The following is a description of a gene set: from publication Yevshin I, Sharipov R, Kolmykov S, Kondrakhin Y, Kolpakov F (PMID 30445619) studied in species Homo sapiens Genes containing one or more binding sites for (ZSCAN4) in their promoter regions (TSS -1000,+100 bp) as identified by GTRD version 20.06 ChIP-seq harmonization. Human Gene Set: ZSCAN4_TARGET_GENES, and this is the list of marker genes: LINC01800, LCP1, GPR156, IL10RA, ZNF567, SMN1, SLC16A5, ARHGEF1, MYL6B, PPCDC, HSPE1, SNORD65C, MEIS3P1 (Meis homeobox 3 pseudogene 1), GOLIM4, TRAV12-1, SMG7-AS1, BOC, PRECSIT, DLX3, TSSK3, HECW2, FAM107B, PRSS23-AS1, STK40, DOC2A, ENSG00000233017, FGD3, LINC01482, UBE3C, HDAC2-AS2, WEE2-AS1, BBOX1, ABHD4, LINC01237, SHISA5, PPM1D, BAG6, IGF1R, RPL26, FAM168A, ZNF827, RNF128, SEPTIN5, SLC44A1, CHRM2, HSDL2-AS1, MDGA1, PLEKHG2, BDP1, GSDMA, HS3ST3B1, DDX1, PGM5P3-AS1, TTC9-DT, ZNF540, NREP, PRPF40B, LINC01366, HOXA3, SSBP4, MIR3677HG, ADRA1A, ALG1, TMEM242-DT, AXL, USP36, ALDH3A1, MSH5, MCOLN1, ECE1, SRP72P2, SERP1, KASH5, TGFB3, DNAJB13, RAP1GAP2 (RAP1 GTPase activating protein 2), TMEM175, CSGALNACT1, HDAC7, ZSCAN16, MSC-AS1, MIR1302-5, TUBA1A, TENM3-AS1, H2AC25, SORT1, INTS9, BLOC1S2, LEMD1, PSD2-AS1, TTC5, LINC01354, EDC3, MAPK10, PCBP2P3, SIPA1L2, RAB5B, PHF1, PTK2B, NSD3, GOLGA6L6, NME1, ELAVL2, LSAMP, HEXA, ZFHX3, SLC7A11, GCC2, CDKN2B-AS1, PAX6, CEP43, RIMBP3C, RGS14, SLCO5A1, ISLR2, NBPF25P, TMEM255A, MTA1, ASXL3-DT, MTFR2P2, PSG5, FAN1, KREMEN1, GJC1, SLC6A15, TARS2, HYCC1, S100A14, C10orf67, POU6F2, DMTN, H2BC15, ITGA9-AS1 (ITGA9 antisense RNA 1), NLGN1, TMEM198B, WDR53, LIN28A, HMOX1, PCSK1N, ZNF345, WWTR1-AS1, APOBEC1 (NCBI Gene Id 339), HSPE1-MOB4, NBR1, SH3KBP1, SNORD74B, RNU6-1110P, PDCD4, ETV4, MIR4276, PSG4, GTF2IP12, KRT7, RBFOX2, DUSP2, TBC1D4, HERC1, RNU6-859P, ATP5MF, PRKG1, GAPDHP71, HEXA-AS1, INTS12, KCNJ5, SCG5-AS1, INO80D-AS1, TCF4, PGM5, RAB11FIP1, MECOM, LRRC45, RBM28, SOX9-AS1, HAPLN1 (hyaluronan and proteoglycan link protein 1), RFX3, GNAL, KCTD5 (NCBI Gene Id 91152), LINC01664, SYBU, MEIS2, C16orf89, FGF9, BRF2, JPX, HDAC5, PRELID1P5, ENSG00000267448, SLC4A1AP, EIF4G1, ENSG00000276170, FGR, PANK1-AS1, LTF, LDLRAD4, JRK, FAM53C, ATG16L1 (NCBI Gene Id 81560), PRPF19, ELN, ISM2, PRKAR1B-AS2, TMCC2, BRSK2, ITGB2, SYT14, DTNBP1, NFIA-AS2, BIRC3 (NCBI Gene Id 330), EBF1, SF3A3, GUK1, HIF3A, IPO11, OSBPL10, FGF7, HIPK2, STMN4, DACT3-AS1, RNPS1, MRPS31P5, ENSG00000225457, ABCC12, BRSK1, MINAR1, MSANTD3, MED23, ALDH5A1, POLR1A, CFL1, DOCK5, EIF2B5, RYR3, UBE2Q2P1, SNRPGP10, GNB2, HAUS5, ZNF513, TGFB2, LRWD1, ZBBX, ATP6V0A2, HOXA10-AS, SGCA, CASC3, LRFN3 (leucine rich repeat and fibronectin type III domain containing 3), MGLL, ST7L, MDFI, CERS5, TXLNB, MIR615, STXBP5L, CXXC4, ZSWIM9, BCL9L, BBC3, SYN2, VSIR, ARHGAP23, SRP54, HUWE1, PEF1-AS1 (PEF1 and COL16A1 antisense RNA 1), SUMF1, CSAD, SLIT1, FSTL3 (NCBI Gene Id 10272), TAB1, CDC42SE1, ZNF461, NR3C1, SLC8A2, GARS1-DT, MGST2, ARID1A, MASP1, DTX4, ELOVL2-AS1, RPS3AP42, RAB2B, JCAD, SSC5D, TRIM52, CEROX1, LASTR, CACNA1D, RNA5SP259, PIWIL4-AS1, KIF11, HAS1, IL2RB, HACD1, SPX, ARAP3, HMX1, FAM117B, MAGI2-AS3, HSPBP1, KCNIP2, TSKU, LGI4, CPEB4, WWTR1, RNF150, RCOR3, ACP2, PHLDA3, ONECUT1, CASP7, FAM151B-DT, STMN3, CARM1, EXOSC7, BSG, RASGRP3, ANXA2, SMG6-IT1, RBM39, VGLL4, ADGRG2, CLASP2, RAI2, LINC01229, IL17REL, TMEM242, KCNH7, ITPRIP, GNAO1, NOS1, INTS14, ATP6V1B2, CTTNBP2, BNC2-AS1, THA1P (NCBI Gene Id 390816), NOTCH2NLA, TFAP4, MIR1301, NSD2, CLPB, TOX4, ENSG00000267260, RNPC3, HOXD3, ATP1A3, NOMO1, SLCO5A1-AS1, HP1BP3, TOR1A, ATPAF2, CARD10, MEIS3, NUTM2B-AS1, FNBP1P1, FBXO45, ZNF395, PBX1, BHLHE40, TRIM2, COL6A2, RAMP3, GBA1, NCR3, PLA2G4A, CHD1, COQ3, MAB21L3, SNAP47, RAB40B, DAZAP1, ARHGAP1, SIGIRR, CEP85, ZNF780A (zinc finger protein 780A), CACYBP, UBE2Q2P12, LINC03068, FYN, CYLD-AS1, VAV1, WDR83, GCC1, RNF220, FAHD1, SSPOP, ATAD3A, GFRA1, TRPA1, LRRC27, FGF13, CELF6, OVGP1 (NCBI Gene Id 8684), TSPAN18, PVALB, CHRNA4, ZNF391, SYNGAP1, ARRB1, KCNJ10 (potassium inwardly rectifying channel subfamily J member 10), CSMD2, DZIP1L (NCBI Gene Id 199221), IRF2-DT, TAF8, CEP170P1, MANSC1, TESMIN, BCLAF1, JARID2, BCL2L13, CABP1, EIF2B3, ALDOA, DCN (decorin), CALCRL, TNFSF12, ZNF331, TSHZ2, ENSG00000249236, GAS7, SEMA6D, DUSP26, ZNF608, ADGRE2, NRN1, EMID1, BBX, SBF1P2, NTF3, WNT5A-AS1, RBFOX3, SOX8, CTNNB1, DHRS13, EXOC3L4, ZNF790, GNAQ, LZIC, BLK, CACNA2D4, SORCS1, RPS27, CTF1, SRFBP1, CENPBD2P, RNU6-918P, SLC7A10, ZYG11A, INIP, SCRT2, GRIPAP1 (GRIP1 associated protein 1), ASPG, PHF21B, SCAP, AFTPH, KRT18P12, MIR6792, KIAA1671, CEBPG, PIPOX, IKZF4, SMYD5, NCOR2, CTF2P, BLTP3B, LINC01235, FAXC, FXYD5, TGM2, ZNF440, DIXDC1, CECR2, NR2F1, ENDOU, CDCA3, TGFBR3L, MTFR1L, PEF1, C2CD5, GNA15, MAML3, PLXDC1, EIF2AK3, MAP2K2, ACVR2A, ANGPT4, HOXD10, CASC9, CHRNA2 (NCBI Gene Id 1135), CEBPB-AS1, LIMCH1, PSTK, SYNPO2, ADGRE5, KCNQ2, KLHL32, HOOK1, GPR89A, C8orf74, LINC01671, IER5L-AS1 (IER5L antisense RNA 1), CAV2, SPRED1, CCDC66, SPG21, GREM2, CHUK-DT, NUTM2A-AS1, KLKP1, MBTPS2, MAD2L1BP, ZKSCAN3, NRON (NCBI Gene Id 641373), TSC1, WNT10A, MIR221, LINC02914, MPPED2, GOLGA6L22, WDR25, LINC02709, NR1H3, ATP5MFP1, FBXL17, SLC1A3, DENND4B, TMEM41A, PROX1-AS1, ZNF860, NTS, ABHD14B, RNU7-27P, DLL3, MRPL39, LINC01270, CASZ1, TMEM25 (NCBI Gene Id 84866), ACBD5, BCL7C, IRF2, NDUFA2, FXYD1, ZNF780B, ERCC1, H2AZP1, SEC14L5, LINC00933, LINC01227, CNTFR, SSBP1, MIR1253, SPPL2B, LINC00431 (NCBI Gene Id 104355135), LAMA3, BTF3-DT, SMG7, SLC36A4, EGLN1, PAK3, RNU6-1145P, ZNF432, MPO, GEMIN6, SLF1, LINC01124, HERC3, TAL1, ASB13, LAMP1, PRR7, INO80B-WBP1, SEMA6A, CD5, GRK1, OBSL1, DMAP1, MRPL1, GABBR1, ENSG00000235281 (novel transcript), LRRK2, XKR9, SMN2, CCDC142, ABCA15P, GGT1, AVPR2, SFMBT2, MSRB2, ATP8A2, RIMBP3, RPS14, NFYC, ADGRG7, KMT2D, SUPT7L, BPI, SLC24A1, CD6, ZNF217, SAP30-DT, ANKRD24, TENM4, FAM27B, GSPT1, ANP32E, C3orf52, DRG2, RPAP3, TRPA2P, ARAP1, LIMD1, EVI5L, AGAP3, SLC35A2, KIF17, EPHX2, HCG27, HEXIM1, GSTCD, UTS2B, LRFN2 (NCBI Gene Id 57497), TUBB2A, MRTFB, LINC01267, SH3BP1 (NCBI Gene Id 84161), NUP98, MEG3, ST8SIA1, CDK2AP1P1, NGEF, KLF7 (NCBI Gene Id 8609), NUCKS1, STRBP, CHRNE, PREX2, FABP5, ITGA8, PPP1R1C, RHCE, TFDP1, IRAG2, RAB11FIP5, CIMIP5, LIN9, PLCB4, ARHGAP28, TNS1, SPATA42, FAM76AP1, PHF12, ATP2B4, ZNF536, UBA1, CRMP1, FBXW7, PYM1, GRB10, FAM98C, TRHDE, OSBPL3, GPC6, SPECC1L, NR1I3, C1orf21-DT, APOLD1, RAB7B, PRR29-AS1, NPEPL1, ASL, DST, PPP3R1, SPINT1, MTAP, LNMICC, FOXP2, HIP1R, HMGB1P21, MACO1, TBXAS1 (NCBI Gene Id 6916), IZUMO1, LCORL, MAX, IK, NFKB2, SMAP2 (small ArfGAP2), MTMR1 (myotubularin related protein 1), SEPTIN9, TBPL1, NHEJ1, EFNA3, CUL2, SIRT6, LINC01107, TPM3P7, KPNB1, KGD4, GPR183, RBBP5, U2SURP, SYN3, MAPK1IP1L, COQ4, CDHR17P, LINC03047, BMF, HNRNPH3, CCND3, SNRNP35, KIAA1217, IRAK4, EPB41L2, CNOT4, BCL7A (NCBI Gene Id 605), SORBS3, EXD2, LINC02845, TRDMT1, SYBU-AS1, KMT2E, FREM1 (FRAS1 related extracellular matrix 1), TMEM182, SHKBP1, NANOGP4, TEFM, FRA10AC1, DMC1, EGLN3, WDR83OS, CCAR2, NHLH1, EPB41L3, SPTBN4 (spectrin beta, non-erythrocytic 4), TRIM62, MGRN1, MYO19, SMYD3, LRRC63, ABCG2, KCNK1, RIMBP3B, ERAP2, ADAMTS19, NHSL3, GRIN2B, FRAS1, RNVU1-15, TMEM91, C6orf226, KLHL23, PPP1R12C, PPIAP74, WSCD1, TMEM238L, PIK3C2B, RFX1, MIRLET7BHG, LRRC74B, CUEDC1, R3HDM2, KIF22, COPZ1, RAET1E, ATP5MC1P7, TAF4, FGD2, ITGA7, ASXL3, IRF2BPL, CITED1, GAPDHP45, ALKBH3, CGREF1 (NCBI Gene Id 378765), GLIS3, LIG1, TMEM100, GRIN2D, NFIB, SNORA72, RS1, AURKAIP1, SAP30, ANK2, SOX5, TTC9, LINC02011, ARHGAP6 (Rho GTPase activating protein 6), THUMPD1 (THUMP domain containing 1), STXBP2 (NCBI Gene Id 6813), UPRT, NUMA1, GPR78, HPDL, NDNF, NOMO2 (NODAL modulator 2), NEFL, RPL23AP66 (ribosomal protein L23a pseudogene 66), PTPRZ1, RHOXF1P3, ARL8A, SLC15A1, MAP3K13, L3MBTL2, PLAAT3, SLC5A2, EPHA10, COPZ2, HAS2, ZFHX4, DPYSL3, GABRB2, GABPB2, SLC6A9, GFI1B, COLQ, RGS5, MTND4P18, NPAS3, ZNF571, KCNJ12, SSH2, EIF2D, TAB2, PAOX, HNRNPU, SOX9, VIT, BCAN-AS2, SAMD14, LINC00963, SYT8, SHANK2, IGLV3-32, SERPINE1, PDE1B, TLK2, OTULIN-DT, MMP16, TRIM7, NOMO3, SMARCA2, PPP3CA, ATP5MF-PTCD1, CDO1, RBMS1, PRKCB, TSC22D4, CUL4A, INO80B (INO80 complex subunit B), CKAP5, MAN2C1, STARD3 (NCBI Gene Id 10948), FCMR, ZCCHC24, TRBV7-6, CYBC1, TCF3, ZNF408, UBAC2, YJU2, MAEL, HPS4, KIRREL2, TLE3, ZBTB4, NAGPA, SMAD7, GTF3C5 (NCBI Gene Id 95853), MXI1, PHF21A, LZTS1, TNNI1, UNC93B1, POLD2, TMSB10, HAS2-AS1, GPR85, SAMD13, GRM1, GGA2, RCOR1, CHRDL2, STUM, SEMA4F, JOSD2, RNU6-1039P, ARHGEF16, NHSL2, JADE2, DAAM1, USB1, RNU6-419P, CTSK, SKP1, LBX1-AS1, CSF1, COMP (cartilage oligomeric matrix protein), DDX55, HIVEP1, ATP2A1-AS1, ATXN1-AS1, DNHD1 (dynein heavy chain domain 1), FAM124A, PLAT, CMTM3, PBX3 (PBX homeobox 3), HMGN3P1, USP9X, MIR6726, IL6R, NDRG1, AMOTL2, DNAJB12, TRIM52-AS1, SPATA13 (NCBI Gene Id 221178), PAX3, GID4, GAL3ST4, KCTD1, CMAHP, PDE4B, FAM43A, RTN4RL2 (NCBI Gene Id 349667), SANBR, SPSB1, SLC35A3, GLYCTK (NCBI Gene Id 132158), ZNF382, ZNF84-DT, LMBR1L, SAXO3, RRN3P2, EIF2B4, HEBP1, NPHP4, NADK2, RAD52, KCNAB2, PTCD1 (pentatricopeptide repeat domain 1), PIGC, ZNF529-AS1, KLHL6, PLEKHG1, SNHG11, PCID2, G0S2, CALCP, HOXD8, IAH1, RN7SKP172, RUNDC3B, NFE2L1, CHRFAM7A, MTMR2, ENSG00000270571, NDUFAF1, HADHA, FMNL1, GDNF-AS1, PLCXD2, NFIX, ITGAM, NFKB1, EMB, ZNF45-AS1, EIF4E3, ETS2, LSM12, LCNL1, CABIN1, ASPSCR1, MYL6B-AS1, PSG11, TTC17, PDE4A, TMEM101, FCHSD2, RGS16, ENSG00000267058, MAF, SELENON, FGF8, PRKCE, GPR162, ENSG00000253607, FHDC1, ARHGEF15, ZBTB38, TSKU-AS1, RERE, OGT, FGF1, BORCS8, NPR3, BRWD1, RFX4, CERS6, KBTBD4, TOP2B (DNA topoisomerase II beta), REXO4, VPS33A, ROPN1, NUF2, UBR2, HMGB1, GTF2B, HAGH, C8orf34, IFNLR1, RPL29, TUBA1C, CD59, JMJD4 (NCBI Gene Id 65094), MAGI2, WDR11, ADIRF, LHX9, NTRK2, NBPF19, DNAJC14, C6orf136, PUS7L, LMO1, BCL2, GRIA2, PPP2R2B, ARHGEF7, PFKL, NOTCH2 (NCBI Gene Id 55574), LINC01605, WEE2, CBR3-AS1, TLCD3B, PLA2G6, ENSG00000243004, SHROOM2, NR2F6, PIK3R3, ZNF529, PNCK, LINC00163, ADNP, DGKG, CRYZL1, RYR3-DT, PDGFB, KCNK10, ENSG00000247416, DTNA, HPCAL1, BTBD19, MSI2, LRRC37B, STAT6, SLC26A4, HPCA, GHR, PKNOX2-AS1, VANGL1, SH3BP2, MAFTRR, MRPS31, TMEM248, EIF3D, RFX3-DT, C11orf96, FOXP1, ARRB2, RUFY1, GNB5, ANK3, ITGB3BP, KSR2, CPNE5, TMEM177, SRSF7, LIMS1, PAX1, MIR378A (microRNA 378a), LINC01003, ZNF546, PLIN3, GAK, FANCC, EBF4, FAT3, CDKL5, KIAA1958, LINC02912, LEPROT, AGBL3, CCNY, LHX6 (NCBI Gene Id 26468), RIMKLB, PAQR9, RCN1, MIR548AW, RBM26, RN7SL310P, LMF1, KIRREL1, CD109, NRIP2, NUDT18, KCNH2, PDZD8, EXOSC3, RABGAP1L, PLA2G10P1, DPH5, RASGRF2, BMP3, PFKFB4, ARHGEF17, ZBTB44-DT, NRG1, DENND2A, PLCH1, CTXND2, CPVL, HSPD1, TBC1D14, RNU6-513P (NCBI Gene Id 106481343), MREGP1, FBXO32, ZFP30, HOXA9, SPOUT1, TRAV12-2, EXOC7, NDUFA5P3, COX16, CCDC146, SNAP25, GDF5, IKBKE, ENSG00000261335, DNAH2, TMEM178A, HOXA-AS2, SCN9A, SNX1, FEZ1, MAPT-IT1, PRRT4, LINC02716, RNU6-570P, RBM26-AS1, IL11RA, DCDC2, CCNE1, CCN3, RAVER1, CHST13, FOXN3, IL1R1, SOX2-OT, GALNT16-AS1 (GALNT16 and EXD2 antisense RNA 1), MSH5-SAPCD1 (NCBI Gene Id 100532732), TOP3B, PDZK1IP1, HMGA1P3, CYLD, IPO9-AS1, HOXC5, PBX3-DT, CD300A, PRSS8, ASIC1, MARCKS, FAM149A, NR2F1-AS1, WNT5A, SPN, CCNI (cyclin I), HS3ST3A1, ZNF740, SCML4, ASB9, STRN, ATP13A2, TRUB2, XKR6, SPAST, TANC1, TBL1XR1, MDGA2, UBE2QL1, EPS15L1, SH3D19, MTUS2-AS1, YARS1, EZH2, MEIS1, LINC01503, NFATC3, SP5, TMEM74B, PJA1, KCTD15, MADD, SPTSSA, BTF3, DIO3OS, TMEM204, DUOX1 (dual oxidase 1), DNAJC5B, IFT56, CDC25C, TIAM2, SMURF1, NOP16, PANK1 (pantothenate kinase 1), DNAJB4, GTPBP3, LEPR, GRAP2, ELP3, ENSG00000248738, ZHX3, HADHB, RHOB, ABI3BP, CLDN1, RCBTB2, ARHGEF28, LURAP1, BORCS8-MEF2B, HYAL4 (NCBI Gene Id 23553), GPM6A, TRARG1, HDAC2, FRMD4B, LMO2 (NCBI Gene Id 8051), LRRC49, NECAP1, GCDH, ZMYND8, SLC22A11 (NCBI Gene Id 55867, solute carrier family 22 member 11), APOD, SEPTIN7P14, R3HCC1L, LINC02332, CSNK1D, CUL9 (cullin 9), GLMP, LEF1, JPH2, F11, DIS3, MGAT1, OR1N2, GCNT2, DCAF1, NFE2L1-DT, CCDC171, PLCB2, ENPP3, DGKK, MYL6, KCNIP1, MAFF, HOXA-AS3, CMIP, RIPOR2, FOXS1, EFCAB7, RN7SL743P, RNU6-470P, VAC14, NME2, CHD3, SEMA3G, ELF2, ADAM10, ANO8, PRDM6, RASGRF1, SLX9, FCHO1, ZFHX4-AS1, BMS1, RAPGEF6, RNF217, GNLY, SCD, MIR6802, USP30, TRBV7-2, ZNF84, ITSN1, ABR (NCBI Gene Id 82701), INSYN2B, PISD, FENDRR, PRICKLE2-AS3, PPIE, LASP1, LINC01781, SOX13, EID2B, BCORL1, SP8, DYRK1A, NCAM1, MSC, PSG8, PAQR9-AS1, PFKFB3, WDR45B, CDC37, CNOT6L, ENSG00000203900, RBM22, SRGAP3, SMARCD3, PLAAT1 (phospholipase A and acyltransferase 1), INHA (NCBI Gene Id 3623), CLDN7, PPP6R1, UBB, ITPK1, WDTC1-DT, LACTB, LLGL2, SEC22B, NMNAT1, RASA1, MLLT11 (MLLT11 transcription factor 7 cofactor), LINC-ROR, CDC42EP4, SLC6A8, NUP160, LEF1-AS1, SFXN5, LHFPL1, TAB2-AS1 (NCBI Gene Id 105378049), VSTM2L, ARHGAP24, ACTR6, LINC01547, NF1, TGFB2-AS1, PCBP2, RTEL1, LDB1, ADAMTS10, LIX1L, TXK, LIPE, RBFA, ACSM1, TRPV1, LINC02268 (long intergenic non-protein coding RNA 2268), NFIC (nuclear factor I C), UGGT1, GPAM, C17orf58, KLHL20, NANOS3, PAFAH1B3, DDR2, ST8SIA4, RTBDN, RARG, CCN5, SERPINA11, ENSG00000232995, POU4F1, DYNC2I2, MACC1-AS1, KLHDC9, MCRS1, TCF7L1, RNU2-17P, UBE2K, TMEM121B, WDR82, NME1-NME2 (NME1-NME2 readthrough), CPED1, ERC1, DISC1 (DISC1 scaffold protein), LINC00322, EMP2, WDR11-DT, S100PBP, RLN2, VOPP1, SLC16A7, APOM, ZSWIM2, LSG1, NFKBIE, MID2, CTU2, ENSG00000259881, ENSG00000250915, ARVCF, CEACAMP4, MIR4418, C17orf75, CDC14A, VPS51, TBPL2, HECTD1, CFDP1, TTC36-AS1, PRSS29P, RNU7-156P, RPL21P44, RFXANK, ADAP2, PSIP1, NOG, NDUFS7, BLOC1S1, RD3, ALDH7A1, GRIK1, CDKN1A, APLP1, FSD1, XPO1, SRSF11, POLR2H, ENSG00000249713, SNX10-AS1, ZNF404, HAUS5-DT, CLSTN3, IGSF9B, CDYL2, WNT10B, BAHCC1, PROX1, GABRA6, ANKRD11, PLPP4, SLC26A2, CUX1, SCPEP1, CELF4, BCL11B, LINC03033, OTULIN, BCL9, GRM4, CCN1, PSMB5, COLGALT2, TENM3, NGFR, DCAF10, C1orf21, DPF1, KPNB1-DT, PPP2R2A, DNAJB6, MTOR, NCDN, DDN